The following is a description of a gene set: Any process that stops, prevents, or reduces the frequency, rate or extent of the chemical reactions and pathways involving a vitamin, one of a number of unrelated organic substances that occur in many foods in small amounts and that are necessary in trace amounts for the normal metabolic functioning of the body. species: Homo sapiens Human Gene Set: GOBP_NEGATIVE_REGULATION_OF_VITAMIN_METABOLIC_PROCESS, and this is the list of marker genes: PRMT3 (NCBI Gene Id 10196), SNAI1, GFI1, AKR1C3, NFKB1, SNAI2